The following is a description of a gene set: Mouse Gene Set: GOBP_INOSITOL_TRISPHOSPHATE_METABOLIC_PROCESS The chemical reactions and pathways involving myo-inositol phosphate, 1,2,3,4,5,6-cyclohexanehexol, with three phosphate groups attached. studied in species Mus musculus, and this is the list of marker genes: Plcb3, P2ry1, Ipmk, Plcg2, P2ry6, Scp2, Itpk1, Gper1, Plcg1, Lhcgr, Itpkb, Plcb1, Myh9, Plcd1, Ptafr, Pou1f1, Inppl1